Given this list of marker genes Olfm1, E130308A19Rik, Irgq, Bptf, Chi3l1, Pxk, Trim5, here is a description of the gene set: studied in species Mus musculus Mouse Gene Set: MIR_6392_5P Genes predicted to be targets of miRBase v22 microRNA mmu_miR_6392_5p in miRDB v6.0 with MirTarget v4 prediction scores > 80 (high confidence targets). from publication Chen Y, Wang X (PMID 31504780)